The following is a description of a gene set: Developmental regression Human Gene Set: HP_DEVELOPMENTAL_REGRESSION Loss of developmental skills, as manifested by loss of developmental milestones. studied in species Homo sapiens, and this is the list of marker genes: DPH5, NECAP1, FOLR1 (folate receptor alpha), NTNG1, IRF2BPL, NBEA, FGF12, TUFM, GABRA5, KCNC2, ERCC4, TRAPPC6B (trafficking protein particle complex subunit 6B), ELN, BSCL2, SIK1, SEMA6B, NRXN1, HSD17B10, SCN8A, STXBP1, AHDC1, WFS1, SMC1A (structural maintenance of chromosomes 1A), SCN9A, MTRFR, MBTPS2, SUMF1, KCTD7, TNFRSF11A, IRF4 (NCBI Gene Id 4592), WASF1, NACC1, TBC1D2B (NCBI Gene Id 91449), HTT, TTC19, KCNB1, PEX10 (NCBI Gene Id 5192), EEF1A2, ADGRV1, SDHD, MT-TK, ATP11A (NCBI Gene Id 84170), CYFIP2, PAFAH1B1, GUF1, SCN2A, GTF2I, TRAK1, MT-ND2, FZR1, EIF4H, GABRG2, NUP54, GNAO1, NDUFA2, CARS2, ARSA, KCNH5, CRLS1, IQSEC2, SCO2, LNPK, ASPA, SMPD1, MECP2, TCEAL1, UBTF, ATP6V1A, GLA, PIGT, KCNT1, SDHB, POLG, PEX6, TANC2, PSAP, SLC29A3, DDB2, POLD1, IL10, IL12A-AS1, AAAS, DNAJC30, MPV17, PIGY, NEUROD2, PCDH19, GAMT, ATP1A2, NAGA, HCN1, MUTYH, MT-TN, LSM11, ACOX1, SGPL1, BMPR1A, UBAC2, EPCAM, HNRNPU, PDE2A, DNM1L (NCBI Gene Id 692222), ATP1A3 (ATPase Na+/K+ transporting subunit alpha 3), PMS2 (PMS1 homolog 2, mismatch repair system component), SLC25A22, CDK19, EARS2, FDXR (NCBI Gene Id 2232), AARS1, ATP6V0C, NCF1 (neutrophil cytosolic factor 1), IDS, PEX3, TPK1, SZT2, TBCE, CHD2, PLCB1, GRIN2B, TPP1, SYNJ1, NDUFS1, FAS, SPTBN1, CLTC, VPS37D, PNKP, NDUFS7, COA8, LRPPRC, CAMLG, EHMT1 (NCBI Gene Id 79813), AMFR, GFM2, ETHE1, SMARCAL1, AIFM1, SCN1A, RNU7-1, ERLIN2, BAZ1B, FBXO11, PIGQ, NTRK2, KARS1, GLB1, NDUFA6, H3-3A, ADH5, POLR3K (NCBI Gene Id 51728), CASK, HNRNPH2, TGFBR2, CNPY3, CHD8, PIK3CA, GABBR2, BICRA, NFU1, POLE, PIGP, SLC25A42, MFF, MT-ND4, FRRS1L, SIN3A, HACE1, TK2, FBXO28, PHACTR1, LIPT1, HIBCH, HPDL, PIGA, XPA, NDUFV1, DTYMK, RNASEH2B, GRM7, STX1B, PCYT2, DNAJC19 (DnaJ heat shock protein family (Hsp40) member C19), CISD2, ERAP1, KRAS, YWHAG, ST3GAL5, GABRA1, ADPRS, GABRA2, SEMA4A, SNAPC4, ITPR1, MT-ND1, GNB1, SURF1, REEP1, IFNGR1, PLP1, PEX1, AMN, ZNF699, EIF2B1, ATP7A, RHOBTB2, GMPPA, WARS2, NEU1, SPTAN1, PACS2, LIMK1, UGP2, TMEM270, CLN8, GABRB2, POLR3B, UBA5, CASP2, GABRB3, BUD23, RPS20, ROGDI, SDHAF1, IL23R (NCBI Gene Id 94006), GM2A, HEXB, FUCA1, TTPA, TFE3, MEFV, SLC32A1, SLC1A2, MT-ND5, CLIP2, WDR45, TANGO2, ERCC5, ATP5MK, MT-TV, PLA2G6, POC1A, COASY, PARS2, GFAP, CD40LG, HSD17B4, NTNG2, AHCY, TYROBP, TRIM8, PET117, CACNA2D1, SNF8, AGTPBP1 (ATP/GTP binding carboxypeptidase 1), CNP, KCNQ2, AGA, COG8, FARS2, IFIH1, TBCD, FAR1, KCNT2, CHEK2, POLR3A, ADAR, CTNNB1, TRAPPC2L, NARS2, IBA57, AP3B2, CLN5, GALC, FOXG1, DEAF1, GCDH, DALRD3, EPRS1, SON, POLR3GL, COX15, WWOX, STAT4, NGLY1, UBAP2L, HEPHL1, SERAC1, TMLHE, TCIRG1, TREM2, SCN3A, TBC1D24, LETM1 (leucine zipper and EF-hand containing transmembrane protein 1), GRIN2D, KCNA1, CACNA1A, VAC14, DNMT3A, NUP214, SLC38A3, CELF2, TBL2, NDUFS2, CDKL5, PYCR2, RNU4-2, MT-ND6, BRCA2, TUBB4A, DHDDS, PEX2, NKX6-2 (NCBI Gene Id 84504), SDHA, CACNA1B, SLC4A10, SAMHD1, TRAPPC11, MT-TW, NDP, GTF2IRD2, SATB1, CHMP1A, KLRC4, GLRX5, PEX5, PEX12, NAXD, MT-ND3, TRAPPC12, IL12A, PTCD3, ISCA2, CAMK2B, FBXW7, FKBP6, FITM2, TREX1, SLC9A6, L2HGDH, SV2A, PMS1, PHYH, ACER3, PEX26, METTL27, C4A, RANBP2, NDUFV2, ERCC2, TLR4, RFC2, ARHGEF9 (NCBI Gene Id 23229), SYNGAP1, MLH1, POLR1A, ACTL6B, MMACHC, CIC, ST3GAL3, IPO8, XPC, BCKDK, COX4I1, TBCK, MSH6, CAPRIN1, CAD, ISCA1, PPP3CA, PEX7, NUS1, EIF3F, ARV1, PEX16, AARS2, DNM1, SELENOI, NDUFS4, NDUFAF6, PEX19, KCNA2, NAXE, MRPL39, SCN1B, CNKSR2, ZBTB20, ADA2, GTF2IRD1, PEX13, ASAH1, ARX, FGF13 (NCBI Gene Id 730528), MT-TL1, CUBN, ERCC3, GRIN2A, NDUFC2, ATM, MT-ATP6, PEX11B, MED27, BOLA3, SLC30A9, CACNA1E, CCR1, MSH2, HLA-B (NCBI Gene Id 730410), COQ8A (coenzyme Q8A), MRPS34, LYRM7, GABRD, ADNP, SLC19A3, CLPB, ASCC3, SLC12A5, STX1A, PMPCB, NUP62, MAPK10, PRRT2, SLC39A14, GABRB1, WLS, ZBTB18, GRIN1, RNASEH2C, CUX2, DMXL2, STN1 (STN1 subunit of CST complex), SLC13A5, PPP2CA, RNASEH2A, NALCN, PEX14